The following is a description of a gene set: The 'de novo' formation of a microtubule, mediated by the microtubule organizing center. Human Gene Set: GOBP_MICROTUBULE_NUCLEATION_BY_MICROTUBULE_ORGANIZING_CENTER species: Homo sapiens, and this is the list of marker genes: CENPJ, TPPP, NIN, CEP192 (NCBI Gene Id 84082), MZT1